The following is a description of a gene set: studied in species Homo sapiens RHOA GTPase cycle Human Gene Set: REACTOME_RHOA_GTPASE_CYCLE, and this is the list of marker genes: ARHGEF17, DAAM1, PKN2, FAM13A, STK10, ARHGEF28, VANGL1, TJP2, ARHGAP8, HMOX2 (heme oxygenase 2), SLK, ARHGEF3, CCDC115, FLOT2, ARHGAP35, SNAP23, ARHGAP42, PIK3R2, FMNL3, SRGAP1, ARHGEF15, TIAM1, BCAP31, LBR, ARHGEF11, ARHGAP44, ANLN (NCBI Gene Id 54443), ERBIN, DEPDC1B, NET1, ARHGAP6, ARHGEF12, ARHGAP30, SCFD1, ARHGAP11B, OBSCN, ARHGAP5, IQGAP1 (IQ motif containing GTPase activating protein 1), RHOA, TMPO, VAMP3, KTN1, ARHGAP24, ARAP3, ARHGAP11A, PLEKHG3, MCF2L, ARHGEF1, PCDH7, ARHGAP18, ARAP2, PKN3, CAV1, ARHGAP10, ARHGAP29, ARHGAP22, ARHGAP26, ROCK2, ATP6AP1, TEX2, ARHGAP20, DOCK2, ACTC1, DLC1, ARHGAP21, ARHGAP19, PREX2, ARHGDIB, ARHGAP23, MACO1, BCR, RTKN, JUP (NCBI Gene Id 3728), ARHGEF7, PLEKHG5, ACBD5, ARAP1, GMIP, FLOT1, VAPB, ARHGAP4, VAV1, FARP1 (NCBI Gene Id 10160), VAV2 (vav guanine nucleotide exchange factor 2), AKAP13, TFRC, ROCK1, DDRGK1, RHPN2, DEF6, ARHGAP40, ARHGAP45, ARHGAP31, ARHGAP9, ARHGDIA, NGEF, ARHGEF4, ARHGAP39, AAAS, TMEM87A, PKN1, ARHGAP32, OPHN1, ARHGEF25, TAGAP, ABR, ARHGEF5, STARD13, ECT2, MYO9B, PGRMC2, PIK3R1 (phosphoinositide-3-kinase regulatory subunit 1), PREX1, ARHGEF18, MYO9A, LMAN1, ARHGEF19, STOM, ARHGAP1, MCF2, EMC3, TRIO, ARHGAP28, IQGAP3, SOWAHC, ABCD3, VAV3, ARHGEF2, STX5, ARHGEF10, STBD1, CIT, DIAPH3, ARHGEF10L, FAF2, DIAPH1, CAVIN1, KALRN, YKT6, STARD8, C1QBP, RACGAP1 (NCBI Gene Id 94651), PLD1, RASGRF2, ARHGEF40, PLEKHG4, MCAM, PLEKHG6, RHPN1